The following is a description of a gene set: species: Homo sapiens Human Gene Set: STAT3_02 Genes having at least one occurrence of the motif NNNTTCCN in the regions spanning 4 kb centered on their transcription starting sites. This matches the STAT3 transcription factor binding site V$STAT3_02 (v7.4 TRANSFAC)., and this is the list of marker genes: SOCS1, GPC3, GRIN2D (glutamate ionotropic receptor NMDA type subunit 2D), HOXB4, ZFYVE9, ADM2, ZC3H18, NELL2, HOXB13 (homeobox B13), VEZF1, CPA4, CCN2, SLCO5A1, PTMS, EGR3, MTPAP, NFAM1, BCL7A, ARAP2, CA10, GABRB1, SP6, BMI1, MIR22HG, UBTF, TNRC6A, ARL6IP6, SENP3, FBN2, PPFIA2, KPNB1, AP2B1, RND1, FLRT1, ASIC4, NCOA5, SCUBE3, ZBTB25, TNFSF18, CALU, TJAP1, RIMS1, MTMR14, PCBP4, CERT1, MID1IP1, FOXO4, NR4A1, ZBTB9, RBPJ, SHOX2, KCNN3, TRIP10, ARHGAP8, MYT1, ZBTB17, SMG7, HS6ST3, MAML1, RGS3, HEYL, TRIB2, EGR1, ARX, DIPK2B, LTA, IRF1 (NCBI Gene Id 96501), VCL, NAPB, MOB3C, IRX5, SET, CPLX2, TM9SF1, CAPZA1, ZHX2, MEIS2 (Meis homeobox 2), TCF7L2, HOXC4, HOXC6, LTBP1, MATN4, WNT4, CRTAC1, VSNL1, MIS12, KCNT2, UPK2, NR1D1, PGF, SDC1, ASIC2, ARF3, BMP4, KAZALD1, FUT8, EPHA7, TSC22D4, NPAS4, NCAM1, WDR81, BNC1, SLC35A5, CHRM1, UBE4B, EIF4E, WEE1, ZNF296, S100A14, YY1, BCAM, SPTBN2, FOSB, KMT2A, ST7L, EIF5A, AP1S2, MBD6, GPHN, KCNN2, IL18BP, TMEM229B, ALKBH6, TMEM37, NAV2, KIRREL3, TAOK2, EIF4G1, ZSWIM8, SV2B, REM2, NDST2, DDIT3, SGMS1, RBPJL, RPUSD4, LRP2, KCNH3, MNT, RNF213, ZBTB11, UQCRFS1, UBR5, MFSD13A (major facilitator superfamily domain containing 13A), HOXB9 (NCBI Gene Id 3219), SPON1, FBXL3, AZIN1